Given this list of marker genes CMC2, CDC42BPA, TMEM65, MELK (maternal embryonic leucine zipper kinase), NMU, MS4A7, CCN4, ESM1, MTDH, BBC3, STK32B, MCM6, TMEM74B, LPCAT1, SERF1A, SLC2A3, PITRM1, NUSAP1, FGF18, TSPYL5, ECI2, FLT1, GNAZ (NCBI Gene Id 2781), RAB6B, RFC4, COL4A2, OXCT1, EBF4, NDC80, SCUBE2, UCHL5, AP2B1, PALM2AKAP2, ALDH4A1, MMP9, ADGRG6, DTL, TGFB3, EXT1, CCNE2, GMPS, IGFBP5, CENPA, PRC1 (NCBI Gene Id 9055), PLAAT1, GSTM3, DCK, DIAPH3, ORC6, here is a description of the gene set: from publication van 't Veer LJ, Dai H, van de Vijver MJ, He YD, Hart AA, Mao M, Peterse HL, van der Kooy K, Marton MJ, Witteveen AT, Schreiber GJ, Kerkhoven RM, Roberts C, Linsley PS, Bernards R, Friend SH (PMID 11823860) Breast cancer patients with the same stage of disease can have markedly different treatment responses and overall outcome. The strongest predictors for metastases (for example, lymph node status and histological grade) fail to classify accurately breast tumours according to their clinical behaviour. Chemotherapy or hormonal therapy reduces the risk of distant metastases by approximately one-third; however, 70-80% of patients receiving this treatment would have survived without it. None of the signatures of breast cancer gene expression reported to date allow for patient-tailored therapy strategies. Here we used DNA microarray analysis on primary breast tumours of 117 young patients, and applied supervised classification to identify a gene expression signature strongly predictive of a short interval to distant metastases ('poor prognosis' signature) in patients without tumour cells in local lymph nodes at diagnosis (lymph node negative). In addition, we established a signature that identifies tumours of BRCA1 carriers. The poor prognosis signature consists of genes regulating cell cycle, invasion, metastasis and angiogenesis. This gene expression profile will outperform all currently used clinical parameters in predicting disease outcome. Our findings provide a strategy to select patients who would benefit from adjuvant therapy. The optimal set of 70 prognostic markers predicting poor breast cancer clinical outcome (defined as developing metastases with 5 years). Human Gene Set: VANTVEER_BREAST_CANCER_POOR_PROGNOSIS species: Homo sapiens